Given this list of marker genes B3GALT6, TGFB3 (transforming growth factor beta 3), SOX9, SMAD3, COL2A1, COMP, POP1, ARSL, BGN, TGFBR1, here is a description of the gene set: An abnormal lack of stability of the cervical spine. studied in species Homo sapiens Human Gene Set: HP_CERVICAL_SPINE_INSTABILITY Cervical spine instability